Given this list of marker genes KLHL22, PRAMEF17, PRAMEF27, FEM1A, ANKRD9, ASB9, PRAMEF7, FBXO31 (F-box protein 31), ANAPC7, KLHL40, NMNAT2, PRAMEF13, PRAMEF22, ARRDC4, A1CF, FBXO4, KLHL12, DET1, RRAGC, KLHL7, PRAME, KLHL18, PRAMEF12, SMAD7, FEM1C, PIK3R1, RICTOR, PRAMEF6, GFI1, SPSB3, FBXO38 (F-box protein 38), NMNAT1, CDC20, FBXO3, CCIN, KLHL2, DCAF1, FEM1B, GAN, KLHL8, KLHDC3, SH3BGRL, SUV39H2, IPP, PCMTD1, PPP1R10 (NCBI Gene Id 5514), KBTBD2, KBTBD12, PRAMEF10, KLHL4, FBXW7, AMBRA1, SKP2, IVNS1ABP, BTRC, KLHL5, KLHL6, SPSB1, PRAMEF11, TUT1, KLHL1, KLHDC10, FBXO46, KLHL30, HSP90AA1, VHL, KLHL29, FBXO7, ASB11, KLHDC1, ARRDC1, KLHL15, FBXO42, PEF1, PRAMEF2, KLHL20, PRAMEF33, SKP1, KLHL11 (NCBI Gene Id 55175), KEAP1, FBXW11, KLHL25, KLHL38, KLHDC2, SOCS7 (suppressor of cytokine signaling 7), FBXL19, FBXO9, KLHL3, ZSWIM8, SPSB4, PRAMEF19, EPC1, PRAMEF20, KLHL23, ASB1 (NCBI Gene Id 51665), MAPKAP1 (NCBI Gene Id 79182), DAW1, PRAMEF4 (NCBI Gene Id 400735), PRAMEF25, FBXO11, RPTOR, KBTBD8, PRAMEF1, KLHL21, KCTD17, PRAMEF9, KBTBD6 (kelch repeat and BTB domain containing 6), KLHL24, PRAMEF15, CDK5RAP3, LRRC75A, HPF1, PRAMEF8, KLHL28, PDCD6, PAQR3, HERPUD1, KLHL35, PPP2R2A, PPP2R2D, DCAF12, SOCS2, ERCC8, PRAMEF18, AXIN1, KLHL17, FBXL4 (NCBI Gene Id 26235), FBXL2 (F-box and leucine rich repeat protein 2), FBXW8, PRAMEF26, RBM47, TRPC4AP, KLHL41, PRAMEF5, DCAF13, KBTBD3 (kelch repeat and BTB domain containing 3), SPSB2, FBXO45, FZR1, DTX3L, KLHL10, WDR77, APPBP2, PRAMEF14, KBTBD7, ARMC5, here is a description of the gene set: An adaptor that brings together an enzyme and its substrate. Adaptors recruit the substrate to its enzyme, thus contributing to substrate selection and specificity. Human Gene Set: GOMF_ENZYME_SUBSTRATE_ADAPTOR_ACTIVITY studied in species Homo sapiens